The following is a description of a gene set: studied in species Homo sapiens Human Gene Set: PULVER_FOREY_PERTURB_ACCUMULATION_LG1 Genes whose depletion leads to accumulation of cells in lG1 (pVal < 0.05) in K562 Repogle et al., 2022 reanalyzed with Velocycle from Lederer et al., 2024 Transcription regulation during the cell cycle is crucial for ensuring genes are expressed at the right time and in the correct amounts, coordinating key processes like DNA replication, mitosis, and cell division. In our study,, and this is the list of marker genes: COQ4, HBD, GATAD1, DIAPH1, PEX19, EXOSC4, S100A13, GPR107, ESS2, NDUFB2, DDX21, USP5, SLC35A1, MBOAT2, ZNHIT6, ACSS2, HSPH1, TCF7L1, THOC3, NOL8, TET2, SRSF11, RC3H2, MRPL17, PIK3C3, CXXC1, HSPA14, PFN1, FUNDC2, PRDM6, INTS3, LUC7L3, SLC7A6, SLC39A9, SURF6, SRP14, HNRNPL, PRDM14, AP1B1, BRIX1, CMTR1, RTRAF, VSIG10, MRPL42, TGIF2LX, TOM1L1, RNF20, MED17, WIPF1, TP53, COMTD1, TBPL1, GLUD2, PIAS3, EPHX2, ETV4, NUF2, COX7A2L, ANKRD39, ALDH1B1, FAM219B, MRPS27, SLC39A8, CMPK2, MRPL34, MTOR (NCBI Gene Id 2476), PPFIA3, ZNF16, HMGB3, TLK2, DNAJC11, EVX2, CLASP1, HIGD2A, HGS, UNC45A, UBE2L6, PKP3, TBC1D7, METTL22, PPA1, ATL3, SUCO, EIF3M, MRPL46, CDK6, FAM53C, FGFR1, PARVB, GBF1, TARS1, MTREX, NOMO1, TSG101, SSRP1, GTF2H3, XPO4, IPO13, TULP4, GALNT5, KANSL2, PSMC1, NAA25, KNTC1, CNOT3, MIOS, TRNT1, GTF3C2 (general transcription factor IIIC subunit 2), EIF4B, EIF5A, LSM2, EXOSC3 (exosome component 3), RAB11FIP1, TAF12 (NCBI Gene Id 6883), ERMP1, ATP5PD, ICE1, MRPL50, LRRC37B, ABCF1, CRTC2, LMX1A, ELP5, CCNB1IP1, MRPL3, ZNF469, ATXN2L, TIMM13, ZNF695, NOP58, TAF10, PPP1CA, TIMM22, PAICS (NCBI Gene Id 647765), GJA3, ACBD5, HJURP, RRAS2 (NCBI Gene Id 22800), PPP2R5A, MED11, SIX6, EXOSC7, PSMD6, STX18, COX4I1, EIF4EBP2, CTBS, INO80B, GFPT1, PGS1, COX11 (NCBI Gene Id 1354), UBE2I, MED24, PPP1R26, ESYT2, ABHD14A, CD46, SLC7A6OS, MAPRE3, ACAD10, DYNLL2, SMAD1, COQ6, ELF4, NPLOC4, METTL14, TPX2, HOXC8, AGBL5, INTS5, GADD45GIP1, PBRM1, NFATC3, HSCB, FOXI3 (NCBI Gene Id 730270), NIP7, CD47, FARSA, RPP21, TAF6, EIF2B1 (NCBI Gene Id 1967), RBBP5, PTCD1, ADNP2, INTS1, KDM5C, ECI2 (NCBI Gene Id 134779), MPV17L2, ARL17A, APH1B, CERK, DSTYK, GSK3B, PTCD3, ACOX1, TAF6L, TELO2, NKX2-5, UGDH (NCBI Gene Id 7358), VMP1, TRMT1L, ZW10, EEF2, METAP2, NKX2-6, MICALL1, DHRSX, ZNF470, ATP5MF, SLC38A2, SNX12, UBA2, MED22, HIPK1, MRPL28, NUP54, AFG2A, SENP6, TOM1, TRAF3IP2, PKN2, MRPL18, ARRB1, SMG5, NT5C2, RCC1, SP2, TMA16, ARGFX, MED16, NELFE, BCS1L, BABAM2, TCERG1, RICTOR, SUPT6H, DECR2, NCKAP1, THRAP3, UTRN, EPAS1, NHEJ1, BTN2A2, TSTD3, ALG11, PSMD13, TNPO3, MED13, WDR77, BCAS2, UBAP1, NDUFB3, TRAPPC10, BFAR, TTC1 (NCBI Gene Id 7265), SRRM1, EPS15 (epidermal growth factor receptor pathway substrate 15), PSMB1, NBAS, VPS39, TUFM, AFG2B, MRPL44, MIF4GD, PAM16, IDH3B, TRMT10C, CAMLG, RCOR1, MRGBP, RNASEH1, FXR2, CD81, MAPKAPK2, GRPEL1, PPAN, FAM136A, ATR, SSR3, CHM, ZMPSTE24, CHMP5, ATRIP, TAF2, LAMTOR2, ADRM1, SNRNP70, NKAPD1, GPBP1, RINT1, PRKCA, UTP18, UQCR10, ADO, POLR2A, RAB8A, CDK2AP2, SACS, SLC25A42, GTF2E1, KIF15, NKX3-2, PRSS57, RARS1, TIMM44, YIPF1 (NCBI Gene Id 54489), SET, TEX10, VPS29 (NCBI Gene Id 51699), UBL5, RPL30, POLG, EGFL7, SMCHD1, RPRD1A, EIF2B3, EIF3H, CCT4, TRMT112, DFFA, AKIRIN1, HNRNPUL2, RPTOR, SRP19, ZNF613, WDR7, GEMIN4, GLB1L2, ST6GAL1, SPOUT1, MSH5, CREG1, NUDT15, BUB3, SEH1L, RBM33, TMEM161B, USP51, NDUFA3, RABGGTA, VARS1, TTI1, PFKL, DNAJA3, PPP1CB, DDX56, RBM17, MIS12, HSP90B1, POLR2I, ITPRID2, F2RL3, AARS2, CD99, PTRHD1, MTX2, WBP11, INTS8, UQCC5, ETHE1, AHCY, DNASE1L1, ISCU, CDC34, FOXD1, AGO1, TTK, NARS1, H4C14, ACIN1, KLF8 (NCBI Gene Id 11279), PMPCB, RNF44, YKT6, FMNL1, RRAGA, TRIT1, ANKRD13C, COX15, RMND5B, PAF1, GOT2 (NCBI Gene Id 2806), SAMD4B, PRUNE1, DENR, NCBP2, BET1, MYBBP1A, PPP1R16B, TSN, SMC6, SP1, UFSP1, CITED2, MARS2, VDAC3, VPS53, EMC7, BLTP1, MTMR1, PSMB2, TRMT5, PRP4K, ATP5F1B, NAPG, ABCE1, ZMYM1, ASAH2B, ZNF334, SACM1L, ARHGEF18, DNAJC7, B4GALT1, PHB1, HOXB3, INTS7, YARS2, RNPS1, PEX6 (peroxisomal biogenesis factor 6), MIER1, KRIT1, TAF1, CHMP3 (charged multivesicular body protein 3), ZNF281, LSM6, ATP5PO, MYBL2, ZNF853, USP32 (ubiquitin specific peptidase 32), LARS1, KDM1A (NCBI Gene Id 23028), RANBP1, ZBTB38, ZNF706, KLF1 (NCBI Gene Id 8055), GPN1, GLE1, PON2, FNIP1, PIP5K1A, HYPK, SLC39A7 (NCBI Gene Id 7922), PARPBP, SALL4, PRELID1, ZNF600, PDHB, WDR18, BOD1L1 (biorientation of chromosomes in cell division 1 like 1), RBFOX2, JPT1, STT3B, MRPL55, FBXO41, DPH2, ZBED1, SELENOM, RANBP3, ANKMY2, RAN, ZNHIT1, NDUFAF3, EHBP1L1, ETS1, GTF2A2, ATF1, HNRNPUL1, POLR2C, TMEM14B, CEP85L, LLGL2, VAX2, ASB3, CENPC, PHB2, MYF6, POLG2, NELFA, ZNF740, SUZ12, OXR1, RRP12, PELP1, TRMT12, NKIRAS2, PHKG1, BCAT1 (branched chain amino acid transaminase 1), EHMT2, MLST8, ZBTB7A, WDR82, SIN3A, PRDM4, RABGEF1, TSEN2, FOXP1, HIF1AN, IPO9, GTF3A, NR2F2, ANKRD13C-DT, ACLY, GCM2, CLTC (clathrin heavy chain), KIFAP3, ZNF81, MRPS28, GTF3C3, USE1 (NCBI Gene Id 55850), CCDC50, URB2, DNMT3A, SEC61G, UBE3C, RPIA, SNRNP35, PTS, SNX24, PDIA4, COA5, SRP9 (NCBI Gene Id 6726), NARS2, NSUN4, FAM117A, AATF, FAM118B, FAR1, GLRX5, PFDN6, HK1, POLR3F, IRF2BP2, CHMP6, UFC1, PGAM1 (phosphoglycerate mutase 1), ARL5A, ADNP, PSMC2 (NCBI Gene Id 5701), SNAPC1, GTF3C4, NRM, PPP1R37, EIF3L, RPL23, CHCHD4, CCDC92, SPATA22, EIF1AX, GATAD2A, NUMA1 (NCBI Gene Id 4926), PRADC1, NHLRC2, ETF1, ZIC4, N4BP1, SNRPD3, OGFOD1, DAD1, CPSF6, HSD17B12, NCAPG (non-SMC condensin I complex subunit G), RAB28, PCYT2, TMEM208, ZBED4, SUOX, PHF23, PDRG1, SCFD1, EPS15L1, KLHL20, HSPD1, GAB2, MRPL19, PSKH1, MAP1B, ERF, HSF2, ACTR2, SNX17 (sorting nexin 17), SRP68, HARS1, GCOM1, ASCC3, TPR, NACA, PSMD4, HNRNPM, RMI2, GRHL1, GET3, VARS2, MRPL24, PCYT1A, ROMO1, WDR5, ATP2C1, GPN3, PGM3 (phosphoglucomutase 3), DDX47, H3C12, PLAUR, MRPS34, MRPL39, PRELID3B, PDPK1, NIPSNAP1, BTBD7, GYPC, RPLP0, ATP5F1D, SMN2, DDX17, RBM6, AP4S1, POLR2F, SERPING1, PABPN1, CLU, YAF2, PET100, N4BP2L2, HECTD4, SRSF10 (NCBI Gene Id 89048), KDM3B, MED4, TBL3, DGCR8, XPO5, TRABD, ZNF653, POU3F3, EIF2S3, PTPN11, SEC61B, HMBOX1, BCL11B, TOR1A, ZRSR2, BMPR2, ATP13A3, FARSB, NAA38, RPSA, HSPBP1, GFER, POLR3K, MNAT1, DRAP1, COG4, NUDT21, SRP54, CYBA, TBC1D12, NUP133, TIMM23B, CHORDC1, NDUFB10, CHSY1, HSPA5, BCCIP, RPL9, SLC25A10, BGLAP, SLC7A5, ZNF594, CEP97, PEX1, TRAPPC4, MRPS11, ETFB, MRPS23, KAT8, INTS9, TIMM9, RNF169, GTF2H1, ZNF644, CUL1, MYO9B, INTS11, DDX19A, ANKRD49, BHLHE40, SKA3, ACTN4, PCNX3 (pecanex 3), HOXB9, DNAJA1 (DnaJ heat shock protein family (Hsp40) member A1), MED10, ATP5F1A, CIAO2A, PIGM, CDIPT, DDX6, EEF1G, FZD3, TMEM242, SNX10, HSPA9, RAD21, YIF1A, MTR, DNAJC8, ARPC5L, CRYAB, EXOSC8, BCL10, PCBD1, EEFSEC, SEC61A1, MTMR2, MRPL27, UBA6, TRIM41, NPC2, PIK3R1, EIF3D, CDK11A, PPFIA1, C16orf95, FTSJ1, RFX7, SLC8B1, SRSF7, DNAJC19, ZFAT, TMX2, TOE1 (target of EGR1, exonuclease), EPRS1, EXOSC9 (exosome component 9), ATG5, DNAH14, CRBN, CCT3, INTU, WDTC1, HMCES, BCR, ERCC3, PEX2, COX14, CA5A, ZNF750, PRRC2A, BDP1, PPP3CC, GOSR2, XPO1, ZNF345, STRAP, EXOSC2, HAPSTR1, CCDC6, DDX39B, MRPS17, NSL1, C20orf203, PAFAH1B3, KDM8, MAU2, TOMM22 (translocase of outer mitochondrial membrane 22), PRKAR2A, DPPA2, TM9SF4, KARS1, SNRPD1, C17orf49, NKX3-1, DDOST, FOXK1, MED7, HNRNPA0 (heterogeneous nuclear ribonucleoprotein A0), SUPT5H, TSR2, WASHC5, COG2, PDAP1, BRPF1, ZIC3 (Zic family member 3), PIGB, PMPCA, RAD54B, PMF1, DYNC1LI1, RAB18, EIF2S1, CTSS, AK4, DHX30, DHX36, FBXO6, MYC, AIG1, MRPL13, PEX13, ZNF14, ARIH2, SPRED2, CTSB, PKN3, GFM1, PITX3, NAA15, PELI1, TADA2B, POGLUT3, GALK2, STMP1, SLC9B2, SLC35A3, EIF3F, THOC7, ARMC8, FOXJ3, EIF4G2, LONP1, PGK1, CTSD, MED6, SRPRB, SNRNP48, MRPL36, PFDN1, STRIP1, MMADHC, PNISR, ZNF683, SFSWAP, GNE, SNRNP40, TFAP4, SLC10A3, FMR1, RAC3, ABCF3, STEAP3, FJX1, DHRS3, FKBP9, MRPS26, NELFCD, SPINDOC, SRCAP, CSNK2B, PDCD7, SMC1A, APOBEC3C, RBM18, SLC25A44, DARS1, WDR1, RPL3, BRCA2, SRP72, RPS9, CMTM4, KANSL3, RAP1GDS1, POLR3B, ATP5ME, POLR1H, SUPT4H1, DLG5, TMEM223, LDB1, VCF1, GOLT1B, AKAP1, MAN2B1, CTR9, HERC1, GET1, BOLA1, CHERP (NCBI Gene Id 10523), VPS37A, ZNF585B, ACVR2B, GTF2H4, GEMIN5 (NCBI Gene Id 25929), CD320, TXNDC17, TGIF1, POLR2M (NCBI Gene Id 81488), ZNF438, ANKRD13D, RPL24, USB1, MED29, MSH2, RPL14, USP7, RPL37A, HSF1 (heat shock transcription factor 1), MRPS2, ERCC2, C1orf131, IRAK4, IQGAP3, ZDHHC7, POLR3C, HOXD8, ALG2, ZKSCAN8, SEPTIN8, LMO2, CCND3, INTS2, ZKSCAN1, SNRPF, SNAPC3, MTHFD1, PPP2R1A, ZCRB1, SCRT1, SAMM50, TMEM115, LSM4, EIF2B5, POU6F2, SFPQ, RARS2, STIL, SLC38A6, RECQL, NTPCR, NDRG2, RFPL4B, MAD2L1, PPP2CB, MPV17, COPE, OXA1L, RNF40, PSMD7, MRPS24, DBR1, EMC4, MZT2A, GNG10, EIF2B2, HIP1R, CDS2, LETM1, HBS1L, SIRT7, AHSP, ARFGEF1, MINPP1, ABCB7, RACK1, HOXB2, LSM5, OR7A10, RCL1, VPS51, VAMP3, SETD7, ELAVL1, FASTK, NELFB, CCDC116, WDR27, NACC1, PLCB3, CES2, NAMPT, COG8, MRPS33, STK11, C1QBP, ATP6V1B2, ANXA3, EIF3E, GTF2E2, NRL, MED12 (mediator complex subunit 12), SPART, CIAO2B, TGM2, RBPMS2, URM1 (NCBI Gene Id 81605), SEC16A, DPYSL2, TMSB10, RBM4, BLZF1, DHDDS (NCBI Gene Id 79947), PROS1, SHOX2 (NCBI Gene Id 6474), SCYL1, SUPV3L1, DHX15, LSM7, MAP4, EIF4E, SON, POFUT2, CERS6, NDUFAB1, HOXD11, RND2, ATP5MG, MED19, NDUFC1 (NCBI Gene Id 4717), MRPL22, ZNF483, IARS2, CLNS1A, MYCBP2 (MYC binding protein 2), NAA20, BUB1B, ALDOA, HS6ST1, U2SURP, DMTN, GP1BB, DGKD, MARS1, MED30, MICOS10, ILRUN, ABHD6, CINP, FURIN, PTGES3, SMIM29, MYO1D, CLK3, TP73, EIF2B4, PNPT1, DOLK, HUS1, ATP6V0D1, MRPL38, TMEM52, BNIP1, SNRPG, FUCA2, PSMD9, GTF2H2, PRPF40A, MED1, ZNF335, ACACA, GALM, CMC4, MKRN3, DDX20, POP4, GLUL, RPL15, RTCB, PRCC (proline rich mitotic checkpoint control factor), GRSF1, CCAR1, WDR26, CCDC71L, TFE3, WDR3, ATP2A2, PLA2G15, COQ5, L3HYPDH, PA2G4, PYURF, MAPKAPK3, PSMD11, ZNF696, AKT2, DOHH, ACO2, NFIX, ARL8A, WDR55, HPS5, SKP2, CLDND1, NUDCD3 (NCBI Gene Id 23386, NudC domain containing 3), MOB4, ADAM10, HSPA8, EED, PROSER2, GNB1L, TUBD1, ZNF669, RPP30, TRAPPC11, MBTPS2, SEC22B, TLCD3A, RAB11A, CKAP5, EXO1, EML3, WDR81, POLL, RPUSD4, UQCC4, FCER1G